Given this list of marker genes RIN2, GLB1, FKRP, OSTM1, SCN1B, PLEKHG2, GNAO1 (G protein subunit alpha o1, NCBI Gene Id 2775), POMGNT1, DMXL2, GRIN1, GMPPB (NCBI Gene Id 29925), TIMM50, POMT2, SLC12A6, KCNA1, VPS11, CDKL5, NEUROD2, PIGQ, PNKP, SCO2, TRIM8, HERC1, CASK, SCN2A, GRM7, HEPACAM (hepatic and glial cell adhesion molecule), SIK1, POMT1, PIGP, SLC32A1, SLC25A22, POMK, HTRA1, ARX, PLP1 (NCBI Gene Id 5354), here is a description of the gene set: Human Gene Set: HP_DIFFUSE_WHITE_MATTER_ABNORMALITIES species: Homo sapiens Diffuse white matter abnormalities